The following is a description of a gene set: Catalysis of the transfer of a methyl group to the oxygen atom of an acceptor molecule. Mouse Gene Set: GOMF_O_METHYLTRANSFERASE_ACTIVITY studied in species Mus musculus, and this is the list of marker genes: Trmt13, Mrm3, Ftsj3, Pcmtd2, Mepce, Pcmt1 (NCBI Gene Id 97645), Fbl, Ftsj1, Comtd1, Bcdin3d, Henmt1, Icmt, Mrm1, Mrm2, Lcmt2, Cmtr1, Lcmt1, Asmt, Cmtr2, Comt, Coq3, Tomt, Armt1, Pcmtd1